Given this list of marker genes Ftl1, Mbp, Tmsb4x, Ccl7, P2ry12, Ptgds, C1qb, Gng11, Apoe, Gstm1, Rhoc, Plp1, Crip2, Lgmn, Clic4, Krt14, Pfn1, Capg, Aplp1, Rpl13, Rpl13a, Tmsb10, Calm1, Gnmt, C1qc, S100a6, here is a description of the gene set: species: Mus musculus Mouse Gene Set: TABULA_MURIS_SENIS_DIAPHRAGM_ENDOTHELIAL_CELL_AGEING from publication Tabula Muris Consortium (PMID 32669714)